The following is a description of a gene set: studied in species Mus musculus The attachment of a mitochondrion and an endoplasmic reticulum via molecular tethers that physically bridge their respective membranes and attach them to each other. The tethering may facilitate exchange of metabolites between the organelles. Mouse Gene Set: GOBP_MITOCHONDRION_ENDOPLASMIC_RETICULUM_MEMBRANE_TETHERING, and this is the list of marker genes: Pacs2, Atp2a2, Pdzd8, Selenon, Calm1, Vmp1, Ahcyl1, Calm3, Calm2, Psen2